Given this list of marker genes CITED2, MYCLP1, TMPRSS3, IL1RAPL1, HDAC7, TBX3, CGREF1, FGF4, TEF, MIR137HG, CTCF, C1orf21, RBM15B (NCBI Gene Id 29890), ELOVL4, ALDH18A1, PRKAG1, RUNX3, SUGP1, AGO1 (argonaute RISC component 1), H1-10, FOXP2, RPS6KA3, FES, KCNA6, PHF8, SLC2A4, FRMD6, LMO1, HSPH1, JADE1, HNRNPF, ZHX2, FBXW9, VPS50, POP1, REPS2, CACNG2, ASIC1, ARHGAP6, MYCL, ABR, ADSS2, TRIML2, PTGR3, SETD7, BAHD1, ATP5MC1, SLC31A1 (solute carrier family 31 member 1), CKB, NOVA2, ATXN7L2, IKZF3, CCDC9B, ARX, EMILIN1, RIDA, IPO4, INPP5A, ARHGEF19, PRR7, SHOX2, FAAP100, AQP5, CAPRIN1, PNCK, CLINT1, TGIF2, GNA14, ZFP91, IRX6, HHIP, PRDM10, UTP4, PAX2 (NCBI Gene Id 5076), ADRA1A, PRDM13, STRIP1, ABCA1, TAF5, LRFN5, SLC6A4, LRATD2, CYFIP2, RFX4, SREK1, NR1D1, MAX, MAP2K7, SPRED1, HOXA13, SMPD3, FXR2, MINK1, here is a description of the gene set: from publication Xie X, Lu J, Kulbokas EJ, Golub TR, Mootha V, Lindblad-Toh K, Lander ES, Kellis M (PMID 15735639) Genes having at least one occurrence of the highly conserved motif M171 CTCNANGTGNY in the regions spanning 4 kb centered on their transcription starting sites. The motif does not match any known transcription factor binding site. species: Homo sapiens Comprehensive identification of all functional elements encoded in the human genome is a fundamental need in biomedical research. Here, we present a comparative analysis of the human, mouse, rat and dog genomes to create a systematic catalogue of common regulatory motifs in promoters and 3' untranslated regions (3' UTRs). The promoter analysis yields 174 candidate motifs, including most previously known transcription-factor binding sites and 105 new motifs. The 3'-UTR analysis yields 106 motifs likely to be involved in post-transcriptional regulation. Nearly one-half are associated with microRNAs (miRNAs), leading to the discovery of many new miRNA genes and their likely target genes. Our results suggest that previous estimates of the number of human miRNA genes were low, and that miRNAs regulate at least 20% of human genes. The overall results provide a systematic view of gene regulation in the human, which will be refined as additional mammalian genomes become available. Human Gene Set: CTCNANGTGNY_UNKNOWN